The following is a description of a gene set: Human Gene Set: KEGG_MEDICUS_REFERENCE_ADRB3_UCP1_SIGNALING_PATHWAY ADRB3-UCP1 signaling pathway. Pathway ID: N01688. Pathway type: Reference. Pathway class: nt06529 Thermogenesis. Pathway Definition from KEGG: ADRB3 -> GNAS -> ADCY -> cAMP -> PKA -> JMD1A+SWI/SNF+PPARG => UCP1 studied in species Homo sapiens, and this is the list of marker genes: ADCY8, UCP1, KDM3A, SMARCD3, ACTB, SMARCB1, DPF3, ADCY9, ADRB3, ADCY7, PRKACA, SMARCD1, DPF1, ACTL6B, SMARCA4, PRKACB, KDM3B, ADCY5 (adenylate cyclase 5), ADCY1, ADCY6, ARID1B, SMARCE1, SMARCC2, SMARCC1, PPARG, ADCY2, ARID1A, SMARCA2, ADCY3, PRKACG, SMARCD2, ACTG1, ACTL6A, ADCY4, GNAS